The following is a description of a gene set: The process in which a relatively unspecialized cell acquires specialized features of a columnar/cuboidal epithelial cell. A columnar/cuboidal epithelial cell is a cell usually found in a two dimensional sheet with a free surface. Columnar/cuboidal epithelial cells take on the shape of a column or cube. Human Gene Set: GOBP_COLUMNAR_CUBOIDAL_EPITHELIAL_CELL_DIFFERENTIATION species: Homo sapiens, and this is the list of marker genes: RARB (NCBI Gene Id 5915), JAG1, RARA, ROS1, DLL1, RPTOR, MAP1B, NR5A2, CEBPB, TJP1, FZD5, TUBB, FAM20C, CCNO, HES1, SPDEF, ZNF800, CEP152, PRDM1 (PR/SET domain 1), ASCL1, C1GALT1, IPO7, TP63, PTK6, BMP7, GATA4, TGFB1, OTP, NKX6-3, WDR77, DLX3, RARG, POU3F2, SAV1, TLR9, CEP63, ONECUT1, GATA2, FST, XBP1, NFE2L1, BHLHA15, NODAL, MIR29B1 (microRNA 29b-1), NPY, GATA5, HIF1A, CTNNB1, FGFR2, SOX11, VAX1, EXT1, SOX9, LHX3, FOXA1, LEF1, ENAM, BCCIP, E2F4, HOXA5, SOX4, CLCN2, BMP2, TMEM231, SLC9A4, PGR, RFX6, IL13, NTF4, MCIDAS, FGF2, CCDC78, ABL1, DLG5, INSM1, GPAT4, PROX1, FOXJ1, MSX1, FGF8 (NCBI Gene Id 2253), NFIB, SERPINE1, NKX3-2, WNT4, TMIGD1, PYY, TP73, IFT80, TTC8, NKX2-2, TIGAR, GATA6, BMP4, DSPP, CDH2, YIPF6, PLK4, PKP1, SMAD2, GMNC, CBFA2T2, YAP1, CDX2, CAV1, B9D1, KLF5, EMX1, IL31RA, SRC, IL6ST, NOTCH1, WNT11, DEUP1